The following is a description of a gene set: Pathway Definition from KEGG: IGF2 -> IGF1R -> PI3K -> PIP3 -> AKT -> MTOR -> S6K IGF2-IGF1R-PI3K signaling pathway. Pathway ID: N00234. Pathway type: Reference. Pathway class: nt06263 Hepatocellular carcinoma. Human Gene Set: KEGG_MEDICUS_REFERENCE_IGF2_IGF1R_PI3K_SIGNALING_PATHWAY species: Homo sapiens, and this is the list of marker genes: MTOR, RPS6KB2, AKT1, IGF1R, PIK3CB, PIK3CA, AKT2, PIK3CD, AKT3, RPS6KB1, IGF2